Given this list of marker genes Gng10, Gng8, Gng12, Gnas, Gngt1, Gngt2, Gng11, Gng4, Gng5, Gnb5, Gnb1, Gng7, Gnb3, Gng2, Gng13, Gng3, Gnb2, Ptgir, Gnb4, here is a description of the gene set: Mouse Gene Set: REACTOME_PROSTACYCLIN_SIGNALLING_THROUGH_PROSTACYCLIN_RECEPTOR Prostacyclin signalling through prostacyclin receptor species: Mus musculus